Given this list of marker genes MAP4K4, ETAA1, ENC1 (NCBI Gene Id 8507), PHF6, ZNF652, THEMIS, IL2, P2RX7, HSPA1B, SNRPB2, THAP11, LYST, RSRP1, ZNF341, ABHD15, RNF115, STIM2, IRF2BPL, ZFAND2A, CDCA5, RASL11B (NCBI Gene Id 79093), RCBTB2, TRIM33, CDC6, ARHGAP26, E2F6, ENSG00000286190, RYR1, TMEM106B, MCM2, VAV3, ZAP70, BAIAP3, TRIM21 (NCBI Gene Id 6737), TFB2M, PHLPP2, PPIF, PTGER4, CDPF1, SEMA4A, FGF13, DIPK2A, LETMD1, LIPT1, CCSAP, VPS13A, ST3GAL6, IRGM (NCBI Gene Id 345611), MCM5, ITGB1, TRIM13, BDH1, PRKCB, EPSTI1, MRPL9 (mitochondrial ribosomal protein L9), RPS29, F2RL1, PTGR3, BUB1, BTLA, DENND4C, TNKS2, HPCAL1, LRP12, SHLD1, CD96, AGPAT3, TUBA1B, HIVEP2, AP1S2, C4orf46, TMCO4, GTF2I, DTL, FCHSD2, ENTPD5 (ectonucleoside triphosphate diphosphohydrolase 5 (inactive)), PAOX, HS3ST3B1, POLH, LAT, TCF7, TYW5, NOD1, KEL, C11orf68, KLF3, BAG4, EXOC6, UNKL, GPC1, RELN, RTP4, EPB41, ASAP1 (ArfGAP with SH3 domain, ankyrin repeat and PH domain 1), CITED2, RPA2, KCNK5, MCTP2, KIF2A, PTCD3, EOMES, MIB2, GMNN, TTYH3, STARD10, TRAT1, AGFG1, GALNT10, USP1, BACH2, ADI1, SLC9A9, KIAA2013, CPNE7, ABTB3, TBL2, RBM6, IVD, SPRING1, FBXO7, WDR12, MBP, TSPYL4, SNHG8, SLCO4A1, UQCC5, ITGA1, TBX21, AAK1 (AP2 associated kinase 1), GMPS, PHF13, SLC12A9, EIF2AK3, TESC, TMEM252, LIMD2, ASF1B, CLTA, CHST2, JMJD6, HCST, TNFSF14, HAUS6, ARFIP1, COX18, SNX5, ST6GAL1, KIAA1143, MYH4, ISOC1, TMEM131L, DZIP1, FBXO32, GIMAP6 (NCBI Gene Id 79765), ORC6, CNST, EVI2A, NFRKB, GCC2, SMYD4, CCDC115, DFFB, RGS3, PDE7A, CHCHD3, RERE, PAG1, RIPOR2, INPP1, TRUB2, G3BP2, SLC20A1, LRRC75B, TBC1D2B, SMAP1, TRIB3, LIN9, C9orf40, C1orf21, INCENP (NCBI Gene Id 56989), ESM1, GPR18, DNAJC6, LEF1, S1PR1, CTSW, SH2D3C, NKG7, TRIM59, STMN1, BMS1, ATP11B, SGSH, RNF144A, TBC1D4, MYO1F, DNAJC15, DGKD (diacylglycerol kinase delta), CXCR3, ESCO2, here is a description of the gene set: studied in species Homo sapiens Comparisons of global gene-expression profiles revealed a greater distinction between CD4+ Treg cells and CD4+ conventional (Tconv) T cells residing in abdominal (epidydimal) fat versus in more standard locations such as the spleen, thymus and LN. Genes down-regulated in comparison of fat tissue regulatory T cells versus fat tissue conventional T cells. from publication Feuerer M, Herrero L, Cipolletta D, Naaz A, Wong J, Nayer A, Lee J, Goldfine AB, Benoist C, Shoelson S, Mathis D (PMID 19633656) Human Gene Set: GSE7852_TREG_VS_TCONV_FAT_DN